The following is a description of a gene set: Human Gene Set: MIR8066 studied in species Homo sapiens Genes predicted to be targets of miRBase v22 microRNA hsa-miR-8066 in miRDB v6.0 with MirTarget v4 prediction scores > 80 (high confidence targets). from publication Chen Y, Wang X (PMID 31504780), and this is the list of marker genes: UBE2V2, PPP1R1C, PTK2, ESYT2, PIGM, NSUN5 (NCBI Gene Id 92116), FUCA2, PEX5L, NIPAL1, PKIG, NET1, PLCB1, PLCL2, ZMYND8, GALNT13, EPSTI1, SLC38A2, SEC62, MGP, PPP4R2, LGALS8, MSH4, WNT16, HSPA4L, MMD, ATP8A1, EXTL2, ACVR1, HIF1A, PHC3, PHTF2, ZNF492, ABT1, MSI2, TSPAN19 (NCBI Gene Id 144448), MAL2, TMEM255A, CYP39A1, NEK3, UNC80, TFDP2, TSC22D2, MRPS14, SLC35A5, FUT9, AUP1, LRCH2, ITGBL1, SLC35A3, AKR1D1, MFAP3L, LPP, ATL1, PALLD, RYR2, DPY19L2, LZIC, C17orf75, FRMD5 (NCBI Gene Id 84978), LTBP2, ABL2, FAM120A, OPRM1, TBRG1, LDLRAD3, ANO4, EBF3, ZBTB20, STEAP4, IDS, HPSE, RC3H1, RSBN1, SLC26A8, SH2D1A, RGS5, TAPBP, TNRC6C, UFSP2, STMP1, AMOT, CYP7A1, RB1 (NCBI Gene Id 92728), SLC66A3, MAGI3, EIF5, OSMR, KAT6A, C1QL3, TRIQK (triple QxxK/R motif containing), DCLRE1C, STEAP2, SESN3, PPTC7, CAMK4, SYNPO2, OPA1, SH3KBP1, CNOT6L, CEP135, NUDC, STAM, NAA50, RIMKLB, ATP13A3, ROBO2, POLG, AFG1L, ZNF333 (NCBI Gene Id 84449, zinc finger protein 333), ABCC1, CNTN3, PIEZO2, CLTC, RHOQ, MFHAS1, CDC42EP3, DNAJC6 (NCBI Gene Id 9829, DnaJ heat shock protein family (Hsp40) member C6), LATS2, LIX1, VSTM2A, TRPC5OS, GSPT1, VANGL1, NEDD9, TFRC, KDM7A, KIAA1143, CERS2, ZNF254, ARHGAP5, THUMPD3, ALDH18A1, LMTK3, AHR, GABRR1, UFL1, IQCB1, TSHZ3, ABI2, REEP3, SIN3B, PAN3, KRAS, HECW1, SP8, FAM114A1 (NCBI Gene Id 92689), SLC25A36, SLC35D3, CRTAP, FAM135A, SLC39A11, RIT1, SLAIN2